The following is a description of a gene set: Human Gene Set: MIR6848_5P Genes predicted to be targets of miRBase v22 microRNA hsa-miR-6848-5p in miRDB v6.0 with MirTarget v4 prediction scores > 80 (high confidence targets). from publication Chen Y, Wang X (PMID 31504780) studied in species Homo sapiens, and this is the list of marker genes: NACC1, TCEANC2, CDK16, INKA2, CRHR1, MMP15 (NCBI Gene Id 4324), ARG1, NDEL1, CMTM5, BMERB1, EIF5A, SCUBE3, USH1G, TPSB2, SYT7, CHP2, DVL3, SIT1, CCDC97, SCRT1, NCOR2, KCNAB2, ADGRL1, PRKCA, OR51E2, NTSR1, RPUSD1, SCNN1A, NCKAP5L, DISC1, SRD5A1, B3GNT7, SHB, WNT1, UBE3A, LSG1, USP21, MPP2, NFIC, ZC3H7B, ABTB2, IL27, ARC (NCBI Gene Id 53837), GPANK1, MIDEAS, TNFRSF10B, LRP10, PDGFB, MYORG, MLF1, NAT8L, OSBP2, SLC8A2, SRRM3, FOXK1, SLC9A1, NCDN, FGR, DCAF12, CASTOR1, TPSAB1, CPLX2 (complexin 2), GEMIN8, CASTOR2, SLC12A4, GALNT6, KCNJ10, NAPA, MDGA1, CHN1, FAM53B, SEC11A, PPP1R9B, CPLX1, PEDS1, SIRPD, RASL10B, HDAC7, PRSS8, LFNG, IGF2 (NCBI Gene Id 492304), SPRED3